Given this list of marker genes Rab38, Ap3b1, Hps4, Abcb6, Ap3d1, Ap1b1 (adaptor protein complex AP-1, beta 1 subunit, NCBI Gene Id 11764), Hps1, Hps5, Ap1s3, Ap1s1, Ap1s2, Ap3m1, Ap1g1, Ap3s2, Hps3, Ap1m1, Rab32, Hps6, Ap3s1, here is a description of the gene set: species: Mus musculus Mouse Gene Set: GOBP_MELANOSOME_ASSEMBLY The aggregation, arrangement and bonding together of a set of components to form a melanosome, a tissue-specific, membrane-bounded cytoplasmic organelle within which melanin pigments are synthesized and stored.